The following is a description of a gene set: Abnormality of the radial head Human Gene Set: HP_ABNORMALITY_OF_THE_RADIAL_HEAD species: Homo sapiens, and this is the list of marker genes: B3GAT3, GSC, KIF22, SLC39A13, SKI, NIPBL, ERCC1, BMP1, NOTCH2, ASXL1, SOX9, ATR, PRKAR1A, B4GALT7, AFF3, SHOX, LMX1B, FZD2, COL5A1, RECQL4, ROR2, COL1A1, CDC45, L1CAM, SCARF2, ESCO2, ARID1B, RNU4ATAC, CHRNG, MAP3K7, COL27A1, EXTL3, CD96, COL5A2, ERI1, NOG, FLNA, DVL1, GPC6 (glypican 6), CHST3, EXOC6B, B3GALT6, CLCN3, WNT5A, EP300, SRCAP, CREBBP, DONSON, TBX15, ANAPC1, IFITM5